Given this list of marker genes TPX2, SGO1, NUF2, HJURP (NCBI Gene Id 55355), INSM1, PENK, CCDC112, PRC1, KIF23, MXD3 (MAX dimerization protein 3), UBE2C, CNR1, HYLS1, CKAP2L, H2BC9, BUB1, NDC80, ECT2, UBE2T, KPNA2, CDK1, FAM83D, NMU, CENPE, NEUROD4, CCNA2, BIRC5, CDCA8, APOLD1, CDCA2, DLGAP5 (DLG associated protein 5), CCNB2, PPP1R17, NCAPH, CENPF, CDKN2C, SPC25, SKA1, here is a description of the gene set: studied in species Homo sapiens from publication Zhong S, Zhang S, Fan X, Wu Q, Yan L, Dong J, Zhang H, Li L, Sun L, Pan N, Xu X, Tang F, Zhang J, Qiao J, Wang X (PMID 29539641) Human Gene Set: ZHONG_PFC_C3_UNKNOWN_INP